Given this list of marker genes PDE6D, SEMA4D, SPRTN, FGFR3, PHKB, HSPG2, ABCB4, PARN, RPL9, DPF2, KCNQ1, IRF2BP2 (interferon regulatory factor 2 binding protein 2), ADA2, STK11, SLC37A4, HNF4A, PYGL, SKIC2 (SKI2 subunit of superkiller complex), RTEL1, BRIP1, AHCY, RABL3, NRAS, DCC, RPS19, SLC25A13, RTL1, SMAD4, BRCA1, PTCH2, ATRX, KCNJ11, PDGFRL (platelet derived growth factor receptor like), RPS17, IL1B, IL12A, RPL18, TMEM231, BRD4, BRCA2, SERPINA1 (serpin family A member 1), BARD1, RPS26, MAN2C1, RPL35A, ZFTA, MPV17, MINPP1, POLE, PDX1, PHKG2, RAD54B, LMNA, ENG, FLI1, IL1RN (NCBI Gene Id 3557), RPL26, WRN, IGF2, PLA2G2A, SOX11, DOCK8, MYC (NCBI Gene Id 731404), PIK3CA, CDK4, MAFA, CR2, TREX1, CASP10, MSH3, CDKN2A, STAT6, MMEL1, RAD50, FLCN, PDGFB, DKC1, TULP3, SMARCB1, TERT, REST, MSR1, BLM, RAD51C, SMO, APC, LZTS1 (leucine zipper tumor suppressor 1), KRT5, GJB2, IGF2R, EWSR1, RPS20, RPS10, MET, TJP2, CD81, PDGFRB, TLR2, SMAD7, AIP, PMS1, TRIM28, ARSA, SEC23B, TNFRSF13B, SMARCD1, AAGAB, HEPACAM, CDKN1C, BLK, MRE11, GIMAP5, AURKA, MSH6, JAG1, ERBB2, H19, BRAF, NEUROD1, SMARCC2, ASL, CEP57, BMPR1A, NOTCH3, BMP6, TNPO3, RNF43, MLH3, MSH2, FGF3, KIT, KIAA0753, DDX59, RSPRY1, TERF2IP, PLCB4, CDKN1B, EP300, COL14A1, TOPORS, PSENEN, DICER1, CCND1, SMARCA4, SMPD1, TP53 (NCBI Gene Id 7157), NPM1, POGLUT1, NF1, FOXE1, ATP2A2, TNFSF12, POU2AF1, SOX4, TYMS, RPL11, SEMA4A, BMP2, CDKN1A, MC1R, SPINK1, FAH, FGFR2, KLF6, VHL (von Hippel-Lindau tumor suppressor), KIAA0586, NBN, DLEC1, PALB2, PTPN3, PKHD1, MYH11, PDGFRA, PPOX, CPLANE1, CDKN2B, RPS29, IL12RB1, HNF1A, NF2, MEG3 (NCBI Gene Id 55384), MEN1, SUFU, OCRL, TCF4, POU6F2, TERC, OFD1, TNFSF15, SPIB, GDF2 (NCBI Gene Id 51423), RPL15, KRAS, ATP7B, GNAS, RPS15A, KIF7, UROD, CASP8, MLH1, IRF1, GATA1, CD19, CREBBP (NCBI Gene Id 1387), PLAG1 (PLAG1 zinc finger), ABCB11, BTK, ACVRL1, USF3, NOP10, SRC, ARID1B, STAT1, EDN1, PHKA2, TMEM216, SDHD (succinate dehydrogenase complex subunit D), RPL35, GREM1, MDM2, SPRED1, CTRC, SKIC3, FASLG, RPL27, CTNNB1 (NCBI Gene Id 1499), DYNC2H1, POT1, BAP1, PAX4, APPL1, CTHRC1, G6PC1, FH, INTU, FAM149B1, CDC73 (NCBI Gene Id 79577), C1S, POFUT1, MUTYH, GPR101, WWOX, PTEN, C2CD3, NUTM1, MBD4, GPC4, KEAP1, BAX, AKT1, CHEK2, COL4A5, AXIN2, DLK1, RPS27, PSAP, DZIP1L, TRIP13, RPL31, NFKB2, PTPN12 (NCBI Gene Id 5782), SDHB, GNAI3, KCNQ1OT1, RPL5, GCK, KLF11, SETBP1, MDM4, NFKB1, IRF5 (interferon regulatory factor 5), RAD51D, GJB6, ARID2, RHBDF2, BUB1B, SLC12A3, MS4A1, MST1, NTHL1, MGMT, RNF6, KAT6B, NHP2, FAS, SLC2A2, RPS24, EPCAM, CPOX, TMEM107, AXIN1, HBB, PALLD, MAD1L1 (mitotic arrest deficient 1 like 1), MCC, CDKN2C, RAD21, CEP120, CLCNKB, POLD1, TRAF7, WDPCP, ROS1, ACD, PTPRJ, RPL8, JAK2, PIEZO2, ASCC1, ZFX, RPGRIP1L, PDE11A, HEATR3, DLC1, BCL10 (BCL10 immune signaling adaptor), BUB1, RPS7, KLLN, CEL, SMARCE1, PMS2, COL4A6, SDHC, TSR2, YY1, CDH1, ATM, RPS28, PTCH1, MITF, GPC3, TCTN3, INS, SDHA, TMEM67, WRAP53, GPR35, HABP2, CTC1, TNFRSF13C, BUB3, ICOS, USB1, ABCC8, ARID1A, INPP5E, ACVR1B, F5, TGFBR2, MTOR, TINF2, HFE, RAD51, NEK1, DIS3L2, WT1, CC2D2A, GCGR, PRKAR1A, HMBS, NAB2, here is a description of the gene set: Human Gene Set: HP_DIGESTIVE_SYSTEM_NEOPLASM Digestive system neoplasm A tumor (abnormal growth of tissue) of the digestive system. species: Homo sapiens